The following is a description of a gene set: Human Gene Set: GOBP_POLYAMINE_METABOLIC_PROCESS The chemical reactions and pathways involving polyamines, any organic compound containing two or more amino groups. species: Homo sapiens, and this is the list of marker genes: OAZ2, SAT1, AOC1, SMS, AZIN2, SRM, AZIN1, OAZ3, SMOX, ODC1, AGMAT, OAZ1, SATL1 (NCBI Gene Id 340562), PAOX, HDAC6, SAT2, AMD1, HDAC10, DHPS